The following is a description of a gene set: Mouse Gene Set: GOBP_RESPONSE_TO_TYPE_II_INTERFERON Any process that results in a change in state or activity of a cell or an organism (in terms of movement, secretion, enzyme production, gene expression, etc.) as a result of an interferon-gamma stimulus. Interferon-gamma is also known as type II interferon. studied in species Mus musculus, and this is the list of marker genes: Evl, Tlr3, Gapdh-ps15, Trim21, Gbp9, Ciita, Cd74, Flnb, Kynu, Dnaja3, Il12rb1, Jak1, Ifitm6, Gbp7, Ifitm1, Gbp2b, Epsti1, Irgm1, Rab20, Parp9, Wnt5a, Gbp4, Cdc42, Was, Stx4a, Rab43, Tnf, Dapk1, Gapdhrt2, Ptpn2, Gapdh (NCBI Gene Id 407972), Kif16b, Irgm2, Stxbp4, Calm1 (NCBI Gene Id 12313), Fasl, Cldn1, Ifitm2, Stxbp3, Sp100, Gbp10, Tlr2, Actr2, Kif5b, Atl2, Shfl, Cd47, Irf8, Sirpa, Syncrip, Cyp27b1, Rab11fip5, Mefv, Gbp3, Rps6kb1, Igtp, Star, Calm2, Slc30a8, Edn1, Mrc1, Tyk2, Vamp4, Cdc37, Camk2a, Zyx, Gbp6, Calcoco2, Calm3, Ifitm7, Bst2, Cdc42ep4, Adamts13, Vamp8 (NCBI Gene Id 22320), Rpl13a, Pde12, Ass1, Ubd, Stx11, Capg, Gbp2, Vim, Rab12, Vps26b, Tgtp1, Pim1, Aif1, Ccl5, Gbp5, Jak2, Stx8 (NCBI Gene Id 80802), Ifngr1 (interferon gamma receptor 1), Myo18a, Trp53, Stat1, Acod1, Ifng (interferon gamma), Hpx, Slc26a6, Atl3, Gbp8, Gpr146, Ifitm3, Cdc42ep2, Stxbp1, Med1, Gimap6, Stxbp2, Daxx, Mir511 (NCBI Gene Id 100124488), Gsn, Otop1, Actg1, Slc22a21, Pparg, Gapdhrt, Il12b, Mst1, H2-Q7, Arg1, Casp1, Parp14, Vamp3, Actr3, Eprs1, Dapk3, Il23r, Slc22a5, Tlr4, Slc11a1, Nlrc5, Myo1c, Cxcl16, Cited1, Ccl2, Irf1, Snca, Slk, Txk, Lcn10, Aqp4, Gch1, Rab7b, Nos2